Given this list of marker genes Tkt, Taldo1, Rpe, Rpia, Shpk, here is a description of the gene set: The branch of the pentose-phosphate shunt which does not involve oxidation reactions. It comprises a series of sugar phosphate interconversions, starting with ribulose 5-P and producing fructose 6-P and glyceraldehyde 3-P. Mouse Gene Set: GOBP_PENTOSE_PHOSPHATE_SHUNT_NON_OXIDATIVE_BRANCH studied in species Mus musculus